Given this list of marker genes H2ac22, H2ac24, H4c1, H4c16, Cenpa, H2ac7, H4c18, H4c4, H2bc21, H2ac8, H2ac4, H4c3, H4c14, H2ac23, H4c2, H4c17 (H4 clustered histone 17), H2ac6, H4c9, H4c6, H2ac13, H4c12, H4c8, Rcc2, H4c11, here is a description of the gene set: studied in species Mus musculus Mouse Gene Set: GOCC_CHROMOSOME_CENTROMERIC_CORE_DOMAIN The innermost portion of the centromeric region of a chromosome, encompassing the core region of a chromosome centromere and the proteins that bind to it.